Given this list of marker genes Recql, Atp2a2, Rps6kb1, Zfp449, Rab11fip1, Kcnma1, Spock3, Ugt1a5, Rock2, 2210418O10Rik, Ugt1a2, A130010J15Rik, Tacr3, Mrpl39, Ak2, Arpp21, Eda2r, Wdr47, Cacfd1 (NCBI Gene Id 77067), Ugt1a6a, Pum1, Far2, Car10, Gabrb3, Hnrnpa2b1 (NCBI Gene Id 71605), Lrrn3, Tnfrsf21, Mast1, Cdc14a, Ppp2r2a (protein phosphatase 2, regulatory subunit B, alpha), Trib2, Ugt1a1, Cps1, Ccpg1, Cxcr4, Fech, Pank4, Lmtk2, Ugt1a10, Fndc3b, Fuca2, Plekhb2, Eya4, Grhl3 (grainyhead like transcription factor 3), Brwd3, Tbc1d31, Chic2, Papss2, Ugt1a7c, Golt1a, Slc7a11, Nox4, Zhx1, Plekha8, Dclre1b, Fam120c, Lpp, Treml2 (NCBI Gene Id 328833), Slco3a1, Tnfrsf9, Sap30, Bend4, Txlnb, Tnrc6b, Larp4 (NCBI Gene Id 52147), Ifi204, Ncam2, Vps13b, Kcnq2, Tpgs2, Bloc1s3, Zfand5, Rabgap1l, Tank, Plag1, Zfp334, Synpo2l, Vps33b, Col9a3, Ncoa4, Shoc2, Zfp68, Ccdc125, Top2b, Gnb4, Nudc, Enpp6, Cplx2, Polr3g, Kansl1l, Napb (NCBI Gene Id 56276), Unc79 (NCBI Gene Id 217843), Col15a1 (NCBI Gene Id 12819), Kera, Ugt1a9, Xkr6, Ccr9, Nkiras1, Hexim1, Kpna1, Pdzrn4, Cartpt, Colec10, Pla2g4a, Ppip5k2, Cnn3, Pfkfb2, D630023F18Rik, Golm2, Psma3, Zfp1009, Sema3a, Crim1, Fmn2, Zfp641, Gtpbp2, Lrrcc1, Prex2, Neu1, Nbeal1, Tmem229a, Lims1, Ngfr, Pcsk2, Ttc14, Aktip, Fbxo5, Adamts12, Huwe1, Sec23ip, Dcun1d3, Wdr64, Pla2g4c (NCBI Gene Id 52126), Trim12c, Pakap, 1700028K03Rik, Lbr, Jakmip3, here is a description of the gene set: species: Mus musculus Genes predicted to be targets of miRBase v22 microRNA mmu_miR_511_3p in miRDB v6.0 with MirTarget v4 prediction scores > 80 (high confidence targets). Mouse Gene Set: MIR_511_3P from publication Chen Y, Wang X (PMID 31504780)